Given this list of marker genes TSG101, UBC, VPS37D, NMT2, VPS37B, MVB12B, UBB, PPIA, VPS37C, UBAP1, MVB12A, UBA52, VPS28, VPS37A, FURIN, RPS27A, here is a description of the gene set: Assembly Of The HIV Virion species: Homo sapiens Human Gene Set: REACTOME_ASSEMBLY_OF_THE_HIV_VIRION